The following is a description of a gene set: Metal ion (zinc) binding. Human Gene Set: MODULE_280 studied in species Homo sapiens, and this is the list of marker genes: MMP2, MMP11, AOX1, CRIP2, ZNF117, CP (NCBI Gene Id 1356), LTF, YY1, MMP1, BMP1, MMP23A, MMP13, SUOX (NCBI Gene Id 6821), CA4, MMP12, HS3ST1, ZNF146, ECEL1, MMP14, ADAM9, MMP3, GALNT1, TRAF3, ANPEP, ZPR1, CA2 (NCBI Gene Id 760), POLR2I, LOXL1, SORD, CA5A, TF, PAH, PTPRZ1 (protein tyrosine phosphatase receptor type Z1), LTA4H, PTPRG (NCBI Gene Id 5793), FASN, MMP10, MMP9, MMP7, PPP4C, AFP, ADAM12, ACE, PAM, CRYZL1